Given this list of marker genes PAK2, SELENOT, CAND1, SRPK2, DICER1, ZBTB43, SLC18A2, MAN2B2, EIF4E2, PLPPR4, ANAPC16, LILRA5, RRN3, CHSY3 (chondroitin sulfate synthase 3), TLE3, ZDHHC18, ABCA1, LRP4, PPP1R14C, PTPN20, CCR5, NDFIP2, DMTF1, CTNND1, OSBPL11, ABLIM1, ZNF195, NUMBL, BNIP5, FMO5, MS4A12, BCL6B, KDM6A, EGLN2, FTSJ1, PSMD12, HNF4A, MED23, ARID4B, SULT4A1, HLA-DRA, CLIC4, SLC38A1, RRP1B (ribosomal RNA processing 1B), BICRAL, SYPL2, EML4 (EMAP like 4), CDH5, SHE, CNST, RALBP1, TMEM87A, ZFHX4, DENND6A, SOS1, SRRM4, LAMP5, TOX, LRRC8C, ZNF365, TMEM263 (transmembrane protein 263), COLEC10 (NCBI Gene Id 10584), PAK5, NOD1, CDK14, NDST3, LUZP1, ZBTB34 (zinc finger and BTB domain containing 34), NR2C1, EFNA5, ZDHHC21, MAX, TMEM215, CRISPLD1, ACTG1, here is a description of the gene set: studied in species Homo sapiens from publication Chen Y, Wang X (PMID 31504780) Human Gene Set: MIR1202 Genes predicted to be targets of miRBase v22 microRNA hsa-miR-1202 in miRDB v6.0 with MirTarget v4 prediction scores > 80 (high confidence targets).